The following is a description of a gene set: Human Gene Set: MIR4251 species: Homo sapiens from publication Chen Y, Wang X (PMID 31504780) Genes predicted to be targets of miRBase v22 microRNA hsa-miR-4251 in miRDB v6.0 with MirTarget v4 prediction scores > 80 (high confidence targets)., and this is the list of marker genes: TBC1D2, FMNL3, PDPK1, TNFAIP8, CHRNA7, TMX4, COL4A3, CCDC6, ZNF667, APOBEC3A, DOCK11, CSTF2, PPP4R1, CEP170B, POLR3F, FAM117B, KCNJ10, MTA2, CHSY1, TCAIM, GABPB1, TENT4B, FAM177B, MCM3AP, SLC6A1, PSME4, GABRB3, SPP1, KLF14, MAP3K20, RNF170, APH1A, STXBP5, SLC26A2, SLC5A7, MAML1, GRIN3A, ATP8A1, RTP1, GPATCH2L, SLC6A2, HOMER1, ARFGEF3, PCBP4, EPSTI1, IRX2, AKT3, TP63, URI1, CYP2U1, KCNA6, UNC5D, PON1, ADSL, DPH2 (diphthamide biosynthesis 2), SOX4, STK11IP, TMEM120B, TMEM67, NCOA3, PPM1E, EMSY, PAIP2, PTGFRN, BTG2, FGF14, LRP6, ZNF644, GALNTL6, SLX4IP, APLNR, TMEM64, PLPPR4, PRPF40A, PTBP3, ANGPT2, SORBS1, CD274, FCGR1A, TMPRSS13, CNTN4, SLC30A4, STK39, IGDCC3, TXNDC11, PHKG2, MAPK14, CHIC1, DCP2, CUL4B, ARL13B, LNPK, EBF3, CAMK1D, TSPAN9, BMPR1A, PTPN14, PTAR1, ARPP19 (NCBI Gene Id 10776), GRIA3 (NCBI Gene Id 2892), RFC3, FRAT2, ERFE, CMAS, KLF12, GOT2 (glutamic-oxaloacetic transaminase 2), RAD18, SEMA3G, CEPT1, CMTM4, TRABD2A, SEC14L1, SHANK2, CCDC117, WAPL, SLF2, TFCP2L1, TSPAN12, BOD1L2, SCML2, BHLHE22, TIA1, VGLL2, CNOT9, SYNPO2, PPARD, SLC25A5, MBD1, CHRFAM7A, MED1, STXBP5L, COL11A1, UNC5C, RAB11FIP2, C1QTNF5, ID1, RAB11FIP1, DCP1A, RBM20, UHRF1, LCOR, YIPF6 (NCBI Gene Id 286451), SLC11A2, POU1F1, DMAC1, EGR3, ATOSA, DGKE, TASP1, CSNK1G1, RICTOR, KRTAP1-5, HCFC1, USP15, LRRC7, EEF2, STRBP, GRM3, NFASC, ZFHX3, SLC35E4, DUT, SESN3 (sestrin 3), NDRG3, SLC35A5, PRKAB2, SCN8A, CLIC6, SEC14L3, ADGRB2 (adhesion G protein-coupled receptor B2), PER1, PAX1, NSL1, VWC2, NBEA, HLCS, ABT1, NUDT16, HSPA4L, RASSF5, MST1L, IRAG1, CCDC50, SPICE1, TSPYL1, BACH2, PPP1R18, DNAJC21, ZCWPW2, THSD4, KBTBD4, CCDC91, LRATD1, FZD3, TMEM168, TSPAN2, CCM2, TMEM132B (transmembrane protein 132B), MAP3K19, RAB2A, EPB41L4A, CCNB2, AAK1, ADCY1, KCNS3, HIC2, PTK2, CERS3, ANGPTL2, STK32C, KLF13, DACT1, TRAF6, DIDO1, IL17RD, NDUFA6 (NADH:ubiquinone oxidoreductase subunit A6), SHROOM2, CCDC39, MYL12B, NBPF3, RERE, TXNIP, ZNF678, DSG2, ZNF230, IKZF2, NETO2, CNOT8, WASHC4, DUSP16, ZSCAN12, SENP7, SLC7A1, MEIS2, TRPS1, GID8, FCGR1BP, AJUBA, FYN, WIPF2, TMEM106C, CCDC28A-AS1, USP2, IL16, SLC2A14, TOGARAM1, HS6ST3, TLCD4, LARP4, TANC2, OSBPL1A, ABRAXAS2, VEPH1 (NCBI Gene Id 79674), SNX4, THSD7B, GNG2, DDHD1, ZIC3, DCAF10, PIAS1 (protein inhibitor of activated STAT 1), MYSM1, DDX52, IDE, NAA15, BCAS1, CYTH3, ARID4A, CLIC5 (NCBI Gene Id 53405), ZBTB7A, CLHC1, BCAT1, SLC17A7 (NCBI Gene Id 57030), CPNE8, ZNF516, SSBP2, ANKRD13A, DNPH1, GRIN2A, RAB3B, FBN1, E2F6, TNFRSF1A, MARCHF8, TRAK2, PLXNA2, MAP1B, TMEM154, PPP1R3G, MIER1, PIP4K2B, RNF24, NEXMIF (neurite extension and migration factor), STK35, TENM3, GALNT15, PCYT1A, SYT15, PRELID2, CYRIA, SLC44A1, PIAS2, CSNK1G3, PCNX1, SIDT2, VRK1, RASSF3, ZNF248, TPM4, NAIF1, SNAPC4, IKZF3, MAGI2, CENPB, NFATC3, FCHO2, PGM2L1, IGSF3, REEP1, DNAJC5B, RNF157, HRH2, NLRP5, FAM78A, MAMLD1, GFRA1, SDC2, ATF3, EIF5A2, BNIP5, TPGS2, UBTF, DOT1L, DPY30 (NCBI Gene Id 84661), FBXO30, GDPD1, KLF6, CACNA1G, TDRD6, ONECUT2, FERMT1, G6PC2, NRP1, PHACTR2, RASGRF2, MTMR9, SLC35G1, KLRG1, ZNF618, PBX2 (PBX homeobox 2), PRKAR2A, PYGO1, ELK1, MBNL3, MYOCD, ANKRD46, TSHZ1, NBPF1, CDADC1, IBTK, PRPF38B, CDK15, LEMD3, TRIM9, MTF1, ALDH6A1, DIO2, RAD54L2, PDE7B, CNOT7, ZNRF3, ANO3, CLTC, STRN, ZRANB1, ZNF239, TRIM5, GABRA4, CLCN4, CUL3, ITGAM, KLF7, SPECC1, POMT2, ADAMTS16, SIPA1L1, ASCC1, SH3TC2, MED13 (mediator complex subunit 13), PHF20L1, KCNB1, EPG5, MAP2K6, LINC00390, C4orf19, ZSWIM5, TLN2, MARK3, YPEL2, MEI4, HDX